Given this list of marker genes LAMP2, CCL5, TTR, LRP10, BIRC5, PPP2R5C, ATP6V0E1, FRG1, PDCD1, RRM1, CDKN2C, CDK2AP1, HASPIN, HSPA4L, BUB1, PTRH2, ADAM8, CHD7, S100A4, PRIM2, ATP5IF1, GALNT4, MRPL43, KCTD9, UBL5, GZMB, PERP, CASP7, EEF1AKMT1, CANX, TSPO (translocator protein), CARHSP1 (NCBI Gene Id 23589), KIF23, S100A10, CAPNS1, GNAS, GBA1 (glucosylceramidase beta 1), DTL, XDH, TNFRSF9, LGALS9B, IL18RAP, GNPDA1, CD8B, PCLAF, TRAPPC1, JAK1, ANXA7, NDUFV3 (NADH:ubiquinone oxidoreductase subunit V3), AK3, LGALS3, CD48, AURKB, ANXA1, GABARAPL1, IL12RB2, RAP1B, BRD7, ITGAX, CDKN2D, CDCA5, NASP, SEC14L1, FHL2, ENTPD1, GCAT, ARL6IP4, ARHGDIB, FAM89B, CISD1, GDAP2, TOP2A, ANXA4, ANXA2, FANCM, TWSG1, MT2A, SNX10, NDRG1 (NCBI Gene Id 7998), LITAF, CRY1, KLRG1, KIF22, AGPAT3, S100A11, NDUFB6, COQ3 (NCBI Gene Id 96592), CKS1B, CLIP2, ZFYVE19, ELOF1, BATF, G6PD, SMPD2, MYB, IL1RL1, ACOT7, PSMD8, BMAL1, ITGA4, FKBP2, CDC25C, CDK2, COMMD2, YBX3, DBI, PRC1, COX17 (NCBI Gene Id 10063), CD68, SNX2, GALE, MRPL27, NCBP1, GLRX, PSMA2, ABCB10, MXD4, DAP, LSM1, HK2, CD9, GZMA, SMAP1, CCNE1, XPNPEP1, LAMTOR5, CCNA2, CX3CR1, SRP14, CTSA, STAB1, GZMK, TNXB, SLC66A3, LXN, RNF14, S100A13, ATP5PF (NCBI Gene Id 63498), PPIB, MRPS17, RPP25L, IRF4, NCAPH, PRELID1, MEMO1, SERPINE2, HMGB2, KLRC1, ANLN, CDCA8, MAP4, MAGOH, TACC3, CRIP2, LACTB2, LGALS1, IRF8, GSTT1, MKI67 (NCBI Gene Id 4288), CTSD, LMAN2, IDH3A, DHRS1, ITGAM, REEP5, CCR2, MTMR1, CDK1, KPNA2, INSRR, ENSG00000286190, CCNB2, CDCA3, DAPK2, DENND5A, MIOS (NCBI Gene Id 54468), ALCAM, BBLN, SPSB2, SMDT1, TXNDC12 (NCBI Gene Id 51060), TMEM160, MIS18BP1, SURF4, MED12L, RORA, IL1RN, P3H4, MSRB1, USO1, E2F8, AURKA (aurora kinase A, NCBI Gene Id 8465), POMP, SIRT2, CCNF, REPS1, TTK, PRRC1, LAT2, here is a description of the gene set: Genes up-regulated in comparison of effector CD8 T cells versus memory CD8 T cells. Human Gene Set: GSE9650_EFFECTOR_VS_MEMORY_CD8_TCELL_UP species: Homo sapiens CD8 T cells normally differentiate from resting naïve T cells into function effector and then memory CD8 T cells following acute infections. During chronic viral infections, however, virus-specific CD8 T cells often become exhausted. We used microarrays to examine the gene expression differences between naive, effector, memory and exhausted virus-specific CD8 T cells following lymphocytic choriomeningitis virus infection. from publication Wherry EJ, Ha SJ, Kaech SM, Haining WN, Sarkar S, Kalia V, Subramaniam S, Blattman JN, Barber DL, Ahmed R (PMID 17950003)